Given this list of marker genes GCK, ADGRA1, LRRC10B, SMIM45, RET, CACNA1E, KSR2, KY, SLC8A2, ENSG00000269091, VWA3A, BAIAP3, PENK-AS1, OPRM1, GJD2-DT, TMEM114, MRAP2, CPEB1, GABBR2, GPR139, GLRA3, LINC02197, TMEM271, PCSK2, CFAP61-AS1, KISS1R (NCBI Gene Id 9291), CDH18, TGFBR3L, PRLHR, SLC35F3, KCNJ6, GOT1L1, ELAPOR1, RLIG1, ALPK2, SLC38A11, MIR7-3HG, ABCG8, TAFA3, GCGR, DRGX, EPCIP, SHISAL1 (NCBI Gene Id 85352), PENK, SAPCD1-AS1, RN7SL180P, PNMT, ARC, VWA5B2, SORCS3, GRM7-AS3, DNAI1, FUT9, ASPDH, RASD2, ATP6V1G2-DDX39B, LINC02248, TPBGL, BRINP1, TMEM190, GALNTL6, BTBD17, C11orf87, CNTNAP5, RPSAP57, RNU6-103P, CFAP90, CACNG3, KCNK9, AGBL4, C2CD4A, ZBBX, ST18, USH2A, FAM135B, HS3ST2, SLC24A2, ANKRD18A, VGF, JAKMIP3, LINC02513, POU2F3, AGBL4-IT1, SLC6A17, CHGA, DPY19L2P4, PLCH2, SLC16A11, NPAS4, KLHL1, VWA5B1, COLGALT2, CARTPT, IL13RA2, GLS2, PANTR1, FBXO2, ADAM29, SERTM2, GLP1R, LMNTD1, TEKT1, CNTN3, PURPL, GABRA1, PACRG, KCTD16, PRR16, RD3, KLK4, KIAA2012 (NCBI Gene Id 339809), PPP1R17, GLB1L3, CNGA3, LINC02994, AKAIN1, CFAP46, CCDC172, CCSER1, here is a description of the gene set: from publication Cao J, O'Day DR, Pliner HA, Kingsley PD, Deng M, Daza RM, Zager MA, Aldinger KA, Blecher-Gonen R, Zhang F, Spielmann M, Palis J, Doherty D, Steemers FJ, Glass IA, Trapnell C, Shendure J (PMID 33184181) species: Homo sapiens Marker genes curated from the annotated cluster as represented in the Descartes Human Gene Expression During Development database. Human Gene Set: DESCARTES_FETAL_ADRENAL_SYMPATHOBLASTS The gene expression program underlying the specification of human cell types is of fundamental interest. The study authors generated human cell atlases of gene expression and chromatin accessibility in fetal tissues. For gene expression, the study authors applied three-level combinatorial indexing to >110 samples representing 15 organs, ultimately profiling ~4 million single cells. The study authors leveraged the literature and other atlases to identify and annotate hundreds of cell types and subtypes, both within and across tissues. Our analyses focused on organ-specific specializations of broadly distributed cell types (such as blood, endothelial, and epithelial), sites of fetal erythropoiesis (which notably included the adrenal gland), and integration with mouse developmental atlases (such as conserved specification of blood cells). These data represent a rich resource for the exploration of in vivo human gene expression in diverse tissues and cell types.